The following is a description of a gene set: Mouse Gene Set: GOBP_INTRACELLULAR_LIPID_TRANSPORT species: Mus musculus The directed movement of lipids within cells., and this is the list of marker genes: Osbp, Scp2, Star, Lrp6, Vps52, Abcd1, Vps51, Cpt1b, Npc1, Abcd4, Ldlrap1, Cpt2, Sgpp1, Slc25a20, Serac1 (serine active site containing 1), Fabp3 (fatty acid binding protein 3, muscle and heart), Tpcn2, Arl8b, Abcd2, Snord60, Plekha8, Cert1, Nus1, Pip4k2a, Abca12, Gramd1c, Relch, Tmem41b, Tspo2, Vps53, Acacb, Abca2, Stard4, Abcd3, Gramd1a, Anxa2, Syt7, Abcg1, Osbpl2, Gramd1b, Vps54, Ldlr, Arv1, Tmem97, Abca1, Vps4a, Pcsk9, Npc2 (NCBI Gene Id 67963)